Given this list of marker genes CYP1A2, TBXAS1, CYP2S1, PTGIS, CYP1A1, ALOXE3, CYP1B1, here is a description of the gene set: Human Gene Set: GOMF_HYDROPEROXY_ICOSATETRAENOATE_DEHYDRATASE_ACTIVITY A hydroperoxy icosatetraenoate = an oxoicosatetraenoate + H2O. studied in species Homo sapiens